Given this list of marker genes Trip13, Lamtor3, Mapk6, Fubp1, 1700025G04Rik, Nup62, Tpp2, Ing1, Dnajc6, Btg2, Tns1, Tmem26, Med14, Raph1, Hoxd3, Zfp330, Nr2f2, Slc24a2, Sema3c, Zfp781b, Ggh, Nppc, Gab3, Clk4, Fbxo25, Gm8369, Itgb3bp, Cdkn1b, Fzd10, Cert1, Usp5, Tdo2, Prkca, Zfp955b, Smurf2, Rimklb, Copg2, Fbxo33, Lrrc20, P2ry14, Pi4ka, Tcaf2, Slc25a40, Gpr63, Rps6ka3, Ccdc6, Gtf2e1, Slf1, Cacnb4, Aff4, Zfp414, Frmpd4, Naa15, Clec2m, Sp3, Pdgfd, Zfp975, Spryd7, Zfp936, Rfx7, Ankrd26, Pard6b, Ubxn7, Zfp119a, Sim1, Ing3, Pcnp, Usp25, Spcs3, Rnase4, Cd200r1, Gstt3, Endov, Tmem39a, Vps4b, Dynlt5, Znrf3, Spink11, Zfp78, Slc6a1, Kbtbd7, Pak2 (p21 (RAC1) activated kinase 2), Pde10a, Ubr3, Ddx3y, Ssx2ip, Nup133, Marchf7, Ddit4, Sh3bp5, Szrd1, Ltn1, Zfp874a, Rassf8, Zfp9, Phldb2, Lpar1, Arhgap44, Cgnl1, Tsc22d2, Lrrc19 (NCBI Gene Id 100410, leucine rich repeat containing 19), Cfl2, Tnfsf10, Abraxas1, Agfg1, Zfp175, Ttc7b, Armc8, Slc38a2, Sec22a, Or4a73, Ugt3a2, Zfp820, Ywhag, Tcaim, here is a description of the gene set: species: Mus musculus Genes predicted to be targets of miRBase v22 microRNA mmu_miR_6516_3p in miRDB v6.0 with MirTarget v4 prediction scores > 80 (high confidence targets). Mouse Gene Set: MIR_6516_3P from publication Chen Y, Wang X (PMID 31504780)